The following is a description of a gene set: Human Gene Set: GOBP_POSTREPLICATION_REPAIR studied in species Homo sapiens The conversion of DNA-damage induced single-stranded gaps into large molecular weight DNA after replication. Includes pathways that remove replication-blocking lesions in conjunction with DNA replication., and this is the list of marker genes: POLH, MSH2, WDR33, PCNA, BRCA1, USP43, POLN, DTL, POLQ, UBE2V1, PRIMPOL, FAAP20, POLD3, USP10, POLDIP2, UBE2NL, USP1, SPRTN, REV1, UBE2A, RAD18 (NCBI Gene Id 56852), ZBTB1, CTBP1-DT, RCHY1, UBE2V2, VCP, POLK, POLI, PARP10, MAD2L2, UBE2B, AKTIP, REV3L, POLE2, POLD1, POLD2, PCLAF, UBE2N